The following is a description of a gene set: Any RNA modification that takes place in mitochondrion. studied in species Homo sapiens Human Gene Set: GOBP_MITOCHONDRIAL_RNA_MODIFICATION, and this is the list of marker genes: TRIT1, RPUSD4, MTO1, METTL8, HSD17B10, NSUN4 (NOP2/Sun RNA methyltransferase 4), TRMT10C, PUS1, GTPBP3, TRMT5, CDK5RAP1